Given this list of marker genes ADH1B, IGFBP1, F12, APOM, CYP4A11, C9, MBL2, HSD11B1, F9, PAH, CYP3A7, AKR1D1, APOB, TDO2, DPYS, APOA1, CPB2, C8A, LPA, CFH, SLC22A1, ADH6, CYP2C8, ARG1, PLG, AQP9, PON3, F2, APOF, AFM, SDS, PCK1, CDO1, SAA4, ASGR2, G6PC1, HPX, LECT2, CYP2C9, HGFAC, SULT2A1, CYP3A4, SLC27A2 (NCBI Gene Id 8523), ADH1C, AHSG, C4BPA, ADH1A, APCS, C6, GC (GC vitamin D binding protein), CFHR4, SERPINF2, HPD, ITIH1, TFR2, CPS1, DHODH, here is a description of the gene set: studied in species Homo sapiens Neighborhood of IGFBP1 Human Gene Set: CAR_IGFBP1 Neighborhood of IGFBP1 insulin-like growth factor binding protein 1 in the CAR expression compendium